The following is a description of a gene set: species: Homo sapiens Human Gene Set: REACTOME_MECP2_REGULATES_TRANSCRIPTION_OF_NEURONAL_LIGANDS MECP2 regulates transcription of neuronal ligands, and this is the list of marker genes: BDNF, MECP2, HDAC1, SST, SIN3A, CREB1, CRH, DLL1